Given this list of marker genes ERLEC1, EPHX1 (NCBI Gene Id 2052), RNH1, METTL16, BLVRA, FABP1, EXT1, CAPG, SLC22A15, RNF217, TMEM158, HSD17B6, GPRASP2, SC5D, PLAGL1, PTPN4, NIFK, MBD2 (NCBI Gene Id 8932), RASGEF1B (NCBI Gene Id 153020), TNFRSF18, CCDC59, TWSG1, GALR3, ATP5MC3, RRAGD, TNFAIP8, EIF2S1, BCL2L15, GABARAPL1, ZNF608, LCP2 (lymphocyte cytosolic protein 2), OMA1, RBM8A, IKZF2, YWHAQ, PFDN1, RPS19BP1, HEY1, FADS6, CTSW, TMEM11, STK38L, TRIM45, NDUFB7, PRKCZ, SSR1, COPS6, MFSD4A, ARL10, PSTPIP2, SFT2D2, SERPINF1, LDAH, KIF5C, PCGF2, FAM124B, ITGB1, MRPL55, GPX1, TMEM154, ETFBKMT (electron transfer flavoprotein subunit beta lysine methyltransferase), INTS9, MYC, INTS12, MXD3, FBXO6, C3orf80, C1orf43, PHTF2, FFAR2, LCLAT1, IER2, DNAJC21, TNFRSF4, AGA, PAM, GBP4, ECM1, PCTP, SLC25A33, FBXO7, CAMK1, SWAP70, MFNG, UFL1, NRP1, COX20, VTN, CD5, SNED1, SELENOM, CCDC136, FKBPL, CDC5L, PARD6G, C7orf57, PRAP1, CAPSL, MAPKAPK3, MAF, TNFRSF13C, DNAH11, NT5E, AADAT, ANKH, TMEM65, LSM10, ATP2B1, NDRG1, BTBD8, GFM2 (NCBI Gene Id 84340), HS3ST1, FCF1, SMPDL3A, SLA, ADSL, NSUN2, HNRNPLL, AFG3L2, ENTPD1, MRPL21, ADAMTS6, HOXA2, CNPY2, GABPB2, GPR83, KRTAP21-1, KCNF1, TMEM185A, LYRM7, SOCS2, AVEN, CDC16, MRPL19, PDIA4, CTNNBL1, TRMT6, TBC1D4 (TBC1 domain family member 4), IRF6, SEC22B, CCER1, AHNAK, RORC, UCHL3, LAMC1, PTER, CIMIP1, IL10, ANXA7, ZNF653, PVT1, CD27, CDKN1C, PPM1L, IFI35, IFT52, REXO2, CD83, OTULIN, ACSL1, SAP18, TAFA3, FAH, ACAA2, ATP6V1F, SCAMP1, PPP1R14B, DUSP16, PROS1, BLOC1S4, MRPS10, MDFIC, BBOF1, GLIPR2, ZNF655, TAGLN3, SERAC1, ETHE1, MTHFS, ITGB8 (NCBI Gene Id 3696), PANX1 (NCBI Gene Id 24145), EXOSC5, KDM1B (lysine demethylase 1B), PRG4 (NCBI Gene Id 787), ANTXR2, ATP6V0D2, ANXA5, ZNF688 (NCBI Gene Id 146542), GANC, C4orf51, RTCB, NDUFA8, NHLRC2, SERHL2, XXYLT1, DENR, ALPK2, MED8, KERA, here is a description of the gene set: from publication Chessler AD, Unnikrishnan M, Bei AK, Daily JP, Burleigh BA (PMID 19201883) Genes up-regulated in skin from BALB/c mice after injection of: control versus Trypanosoma cruzi (strain G). studied in species Homo sapiens To investigate the early host response triggered by three different strains of Trypanosoma cruzi at a local infection site, changes in host gene expression were monitored in a murine intradermal infection model using Affymetrix oligonucleotide arrays. Robust induction of IFN-stimulated genes (ISGs) was observed in excised skin 24 hours post-infection where the level of ISG induction was parasite strain-dependent with the least virulent strain triggering a muted IFN response. Infection of mice immunodepleted of IFNγ-producing cells or infection of IFNγ-deficient mice had minimal impact on the IFN response generated in T. cruzi infected mice. In contrast, infection of mice lacking the type I IFN receptor demonstrated that type I IFNs are largely responsible for the IFN response generated at the site of infection. These data highlight type I IFNs as important components of the innate immune response to T. cruzi the site of inoculation and their role in shaping the early transcriptional response to this pathogen. We used microarrays to detail the local host transcriptional response to intradermal T. cruzi infection in WT mice and mice depleted of NK cells, or deficient in IFN-gamma or type I IFN responses. Additionally we compared the local host-transcriptional response generated to infection with 3 different strains of Trypanosoma cruzi (Y, Brazil, and G). Human Gene Set: GSE13522_CTRL_VS_T_CRUZI_G_STRAIN_INF_SKIN_UP